Given this list of marker genes AQP1, MLLT6, INPP5K, AQP2, AQP3, HAS2, HYAL2, AQP6, here is a description of the gene set: Human Gene Set: GOBP_RENAL_WATER_TRANSPORT species: Homo sapiens The directed movement of water (H2O) by the renal system.